Given this list of marker genes Nrp1, Map2k2, Csnk2a2, Map2k1, Csnk2b (casein kinase 2, beta polypeptide), Pak1, Itgb3 (NCBI Gene Id 268495), Itgb1, Csnk2a1, Mapk1, Itga2b, Vav2, Fgfr1, Itga9, Mapk3, Itgav, Rac1, Itga5, Egfr, here is a description of the gene set: Mouse Gene Set: REACTOME_SIGNAL_TRANSDUCTION_BY_L1 Signal transduction by L1 species: Mus musculus